Given this list of marker genes ABCD4, MTR (5-methyltetrahydrofolate-homocysteine methyltransferase), CBS, MTHFR, PRDX1, MMACHC, LMBRD1 (NCBI Gene Id 55788), HCFC1, MTRR, MMADHC, ASPH, here is a description of the gene set: Human Gene Set: HP_HOMOCYSTINURIA An increased concentration of homocystine in the urine. Homocystinuria studied in species Homo sapiens